Given this list of marker genes ADRB3, NR1D2, B3GALT2, CREBRF, PTGFR, TCTA, RSRP1, C16orf74, FBXO45, CCNG2, HMGB2 (NCBI Gene Id 3148), TXNIP, ABCA1, GAB1, SIX5, KLHL24, PIK3C3, TAB3, ETFBKMT, here is a description of the gene set: Human Gene Set: SARTIPY_NORMAL_AT_INSULIN_RESISTANCE_DN from publication Sartipy P, Loskutoff DJ (PMID 14530283) Genes down-regulated in 3T3-L1 cells (adipocyte) by insulin which continued to respond normally to insulin in the insulin resistant cells. We have employed microarray technology using RNA from normal 3T3-L1 adipocytes and from 3T3-L1 adipocytes made insulin-resistant by treatment with tumor necrosis factor-alpha to identify a new class of insulin-responsive genes. These genes continued to respond normally to insulin even though the adipocytes themselves were metabolically insulin-resistant, i.e. they displayed a significantly decreased rate of insulin-stimulated glucose uptake. Approximately genes/expressed sequence tags (ESTs) were screened. Of these, genes/ESTs were identified that became insulin-resistant as expected (e.g. Socs-3, junB, and matrix metalloproteinase-11). However, genes/ESTs continued to respond normally to insulin. Although some of these genes were previously shown to be regulated by insulin (e.g. Glut-1 and beta3-adrenergic receptor), other novel insulin-sensitive genes were also identified (e.g. Egr-1, epiregulin, Fra-1, and ABCA1). Real-time reverse transcription-PCR analysis confirmed the expression patterns of several of the differentially expressed genes. One gene that remained insulin-sensitive in the insulin-resistant adipocytes is the transcription factor Egr-1. Using an antisense strategy, we show that tissue factor and macrophage colony-stimulating factor, two cardiovascular risk factors, are downstream EGR-1 target genes in the adipocyte. Taken together, these data support the hypothesis that some signaling pathways remain insulin-sensitive in metabolically insulin-resistant adipocytes. These pathways may promote abnormal gene expression in hyperinsulinemic states like obesity and type II diabetes and thus may contribute to pathologies associated with these conditions. species: Mus musculus